The following is a description of a gene set: studied in species Homo sapiens Human Gene Set: HP_THYROID_DEFECT_IN_OXIDATION_AND_ORGANIFICATION_OF_IODIDE Thyroid defect in oxidation and organification of iodide, and this is the list of marker genes: IYD, TG, DUOXA2, SLC5A5, TPO, DUOX2